The following is a description of a gene set: The gene expression program underlying the specification of human cell types is of fundamental interest. The study authors generated human cell atlases of gene expression and chromatin accessibility in fetal tissues. For gene expression, the study authors applied three-level combinatorial indexing to >110 samples representing 15 organs, ultimately profiling ~4 million single cells. The study authors leveraged the literature and other atlases to identify and annotate hundreds of cell types and subtypes, both within and across tissues. Our analyses focused on organ-specific specializations of broadly distributed cell types (such as blood, endothelial, and epithelial), sites of fetal erythropoiesis (which notably included the adrenal gland), and integration with mouse developmental atlases (such as conserved specification of blood cells). These data represent a rich resource for the exploration of in vivo human gene expression in diverse tissues and cell types. Marker genes curated from the annotated cluster as represented in the Descartes Human Gene Expression During Development database. studied in species Homo sapiens Human Gene Set: DESCARTES_FETAL_LUNG_MEGAKARYOCYTES from publication Cao J, O'Day DR, Pliner HA, Kingsley PD, Deng M, Daza RM, Zager MA, Aldinger KA, Blecher-Gonen R, Zhang F, Spielmann M, Palis J, Doherty D, Steemers FJ, Glass IA, Trapnell C, Shendure J (PMID 33184181), and this is the list of marker genes: THBS1, HBD, CD84, HPSE, BBC3, ENSG00000212206, AQP10, XIRP2, GP1BA, HEXIM2, HEMGN, TLN1, VCL, KEL, XK, CNST, SLC2A3, HERC2P4, PTGER3, SUCNR1, WFDC1, PLXNB3, RUFY1, C11orf21, KIAA0513, MARCHF2, TSPAN32, PDGFA-DT, PLEK, CCR4 (NCBI Gene Id 1233), ZNF792, TREML1, ATP2C1, LINC02267, DGKG, EXOC3L4, EGF, SYTL4 (synaptotagmin like 4), GMPR, LRP12, MFSD2B, STRIP2, LEFTY1, TUBA8, PTCRA, TUBB1, NRGN, MYO18B, RIPOR3, RHD, LTBP1, F2RL3, RAB37, PCP2, LINC02770, TRAPPC3L, NFE2 (nuclear factor, erythroid 2), ZYX, RHAG, ZFPM1, C2orf88, SRC, SMG1P4, TAL1, CTSA, GAS2L1, WHAMMP2, PDE3A, GFI1B, TMEM91, RILP, ILK, GCSAML, PTGIR, RPL17P22, CXCR2P1, RGS18, ADCY6, MFAP3L, OR2W3, SSX2IP, CLEC1B, EFCAB13-DT, NBEAL2, TMCC2, FAM110A, GP5, GUCY1B1, LINC00642, TGFB1, HYAL3, ENSG00000227355, ENPP7P10, NT5M, NLK, P2RX1, TBXA2R, DGKD, TMA7B, LINC02284, PPBP (NCBI Gene Id 90374), TNNI3, CD226, UBL4A, FERMT3, CA3-AS1, MACIR, LINC00989, E2F1 (E2F transcription factor 1), LYL1, ENSG00000258803, RN7SL30P, TNFSF4, RBPMS2, ANKRD9, SMOX, MPL (MPL proto-oncogene, thrombopoietin receptor), CR1L, CMTM2, PF4, LY6G6F-LY6G6D, LGALSL, RAP1B, H2BC15, ITPRID2-DT, LINC00534, CHRNA2, LGALS12, RAB27B, ACRBP, PDLIM7, TFR2 (transferrin receptor 2), EFCAB13, ENDOD1, MPIG6B (NCBI Gene Id 80739), GATA1, SELP, FLNA, NEXN, PLEKHF2, DNM3, LAT, HGD, ENSG00000258422, GP9, MOB3C, BMP6, BEND2, CXCL3, ITGB3, MPP1 (MAGUK p55 scaffold protein 1), RTN2, ANKRD55, CMTM5, ENSG00000233968, LINC01594, LINC00504, ERVK9-11, LY6G6F, LINC02884, INHBA-AS1, MYOM1, PLXNB3-AS1, ING5, CTNS, SLC39A3, INSIG1-DT, HTR2A (5-hydroxytryptamine receptor 2A), ANK1, F2R, TRIM58, VIL1, KCNQ4, PRKAR2B, P2RY1, ITGA2B, MLC1, MAX, GP6 (glycoprotein VI platelet), NT5C3A